Given this list of marker genes CDK5, CDC42EP2, BMPR2, ARHGAP44, RPH3A, WASF1, AAMDC, CFI, MYOT, PITX2, TRPV6, ATP6V0B (ATPase H+ transporting V0 subunit b), ODF1, TES, NRGN, B4GALT1, IGF2-AS, CDC40, HTN1, DDX17, MEIS1, ARHGEF15, STC1, IRX2-DT, NR3C2, LHFPL1, MSI1, ZCCHC10, RHBDF2, NCOA2, ZIC4, CBX4, UGGT1, FGF13, ZNF462, IQUB, MNT, ATP5MC2, TBX21, BMP1, ASXL1, PCBP2, TMEM88, JARID2, IGF1R (insulin like growth factor 1 receptor), HNRNPA3, SLC25A17 (solute carrier family 25 member 17), IGFBP6, CDC42EP3 (CDC42 effector protein 3), FLI1, EPB41L4B, SERTAD3, PELI3, NNAT, LRRTM3, SMYD2, DRD3, GNB2, ALKBH6, HOXB8, PALS2, GPBAR1, NKX2-8, IL1RAPL1, JADE2, NDUFS2, GPM6A, RNF214, SPRY1, GIGYF2, STAC2 (NCBI Gene Id 342667), SYNE2, EFNB3, PRKAB2, SPAG9, TMED10, ZKSCAN3, CEMIP2 (NCBI Gene Id 23670), GGT6, ALX4, KCNQ4, SLC35A2, NEK6, KCNJ15, PRRC2A, MSTN, FBXL19-AS1, PTPRF, AUTS2, DPF2, SKIDA1 (SKI/DACH domain containing 1), TMEM69, TAC3, SLC4A2, ST8SIA3, IKZF2, ANGPT1, PLEC, BMP4, MATN1, VAMP8, OTULINL, JPH4, GRM3, RYR1, CNTLN, DYRK2, ATXN7L2, RBP5, CALD1, PNOC, RHBDL3, SH2B3, DLX2, HOXC11 (homeobox C11), MAP3K20, PRICKLE1, FOXD3, MYOCD, ARG1, BDNF, PRDM13, RARG, CDC27, MED26, SLC39A8, IL11RA, SYCE1, SLC43A2, TFAP2C, PRR7, HNF1A, HOXA2, ITGB4, RALGPS2, FUT8, IRX4, SCNM1, CIART, DENND6A, ROCK1, TERF2, CLASP1, EVPL, ATP2C1, LINC01567, TMEM178A, BNC2, MYH13, HNRNPA0, DEXI, ZFYVE1, OTP, IP6K2, FAM50A, STAG2, GPR85, COX7B, AHNAK, LZTS2, CC2D2B, TMEM229B, ANGPTL7, GFRA1, MED1, MYPN, S100A9, ASPA, HSD11B1, PPFIA2, CA7, IRX2, RFX4, TNFSF18, PDCD10, EVX1 (even-skipped homeobox 1), SHTN1, DUSP6, GDI1, GPC3, GLS, SOX2, DLG2, FOXO4, LYSMD1, RNF152, GPR142, EIF5A, GPD1, HOXB1, RAB6C, BAHD1, ANXA9, PLCB2, SLC44A4, FAM193B, XYLT2, DCAF8L2 (DDB1 and CUL4 associated factor 8 like 2), EFCAB5, MYL11, ZNRF1, TIMELESS, HSD17B11, FAM107B, RAX, ADAMTS4, PPARG, FURIN, PPP2R5D, DMPK, IRF9, NRG2, HES1 (NCBI Gene Id 3280), ITGA2, PDGFRB, WDR12, TCF4, PVALB, IMPA2, CDK2AP1, RASA2, PLP2, MPRIP, HOXC5, TNNT1, ITGA7, NRP1, HAPLN1, NOVA1, MAB21L2, KCNJ10, ATP2B3, WNT11, HLX, CDH13, DYNC1H1, TMEM204, KCND1, RSF1, SPEG, MEF2C, RTN3, TENT4B (NCBI Gene Id 64282), TEAD2, NECTIN1, RBFOX1, FOXN3, EPHA2, FBXW11, CCDC91, TRIM63, SHANK1, FGF10, EYA1, PDE2A, HOXA3, POU3F3, SERPINI1, CARF, FBXL19, PANK1, FBRS, RBM39, C22orf31, CXXC5, TNFRSF19, NLGN3, ENO2, CLSTN3, PTPN4, PPP4R2, here is a description of the gene set: Genes having at least one occurrence of the motif TTTGGGAGR in the regions spanning 4 kb centered on their transcription starting sites. This matches the transcription factor binding site V$LYF1_01 (v7.4 TRANSFAC). studied in species Homo sapiens Human Gene Set: LYF1_01